The following is a description of a gene set: Human Gene Set: HP_HAND_MONODACTYLY Hand monodactyly studied in species Homo sapiens, and this is the list of marker genes: BTRC, FBXW4, SEM1, BHLHA9, TBX5, EPS15L1, TP63, DLX6, DLX5, CHD7, WNT10B